Given this list of marker genes ALKBH3, ALKBH4, FTO, ALKBH2 (NCBI Gene Id 121642), ALKBH1, here is a description of the gene set: Human Gene Set: GOMF_DNA_DEMETHYLASE_ACTIVITY Catalysis of the removal of a methyl group from one or more nucleosides within a DNA molecule. species: Homo sapiens